The following is a description of a gene set: Human Gene Set: GSE27786_BCELL_VS_ERYTHROBLAST_UP Each fraction of mouse hematopoietic cells was purified by cell sorting from bone marrow of 8-week-old C57BL/6 mice, and its gene expression was analyzed. Genes up-regulated in comparison of B cells versus erythroblasts. from publication Konuma T, Nakamura S, Miyagi S, Negishi M, Chiba T, Oguro H, Yuan J, Mochizuki-Kashio M, Ichikawa H, Miyoshi H, Vidal M, Iwama A (PMID 21540074) studied in species Homo sapiens, and this is the list of marker genes: GALNT4, C3orf33, SBNO1, MFSD3, SLF2, PSMB4, NELFA, WASHC4, EDARADD, CCT7, POLR1C, NUDT18, C2orf68, FHOD1, NOP56, CFDP1, KMT5B, TAP2, CORO1C, SCAP, TRAF3IP2, KLF6, RAP2B, ZFP36, SRF, SNX19, RTCA, PJA1, CITED2, CNPY3, PGLYRP2, FAM91A1, ARB2A, MRPS31, CBX8, TM6SF1, CLUAP1, FLOT1, VPS45, CACUL1, LTN1, MAPK11, FKBP4, PIK3CG, MRPL45, AP3B1, SCAMP2, KCNQ1OT1, RCCD1, MED31, PDK1, PDPR, SIK3, CYP39A1, ZDHHC4, DGAT1, EFR3A, TSKS, MAGI2, SOCS7, ZNF48, TWNK, PRXL2B, ALKBH7, ZNF862, PLPP6, RHOT1, CWC15, FOXRED2, PIGF, GMDS, PRR3, IPCEF1, PDE4DIP, MBD1, PHB2, NTHL1, KLC1, UBXN4, NGRN, PDLIM1, CYP51A1, YWHAB, ENTPD5, ABHD6, COMMD8, ZNF383, GUSB, NDUFS3, OPA1, MLX, LMO4, ZDHHC9, CCR5, EBP, SF3A3, GYG1, FOXN2, ATP8B2, DDX46, DUSP16, TTC39B, ABHD11, BAX, LYAR, LONRF1, MED13, HSD17B4, OSM, ACP5, MAPK9, ECSIT, CENPS, MEF2D, IKZF1, IMP4, WDR77, STX16 (syntaxin 16), ALDH6A1, IER3IP1, PSMA3, PTPN2, CHML, UBA6, MANF, MCFD2, CHTOP, POMP, MRPL22, NFATC3, MNT, APPBP2, ACD, ZNF32, ATP5F1A, NABP1, PI4K2A, GLB1L, MRPS25, BCL2A1, KNOP1, PRKAB2, JAGN1, TRA2B, KCNK6, NOL8, STRAP, IMMP2L, NCOA2, GSKIP, RNF115, CHD3, STYX, PEX1, LENG9, NCOR1, API5, YIF1A, NUDT3, DDX39B, UBTD2, BCAR3, IFT172, TIMM21, ZNF771, RUVBL2, MLLT1, MDP1 (NCBI Gene Id 145553), TAPBP, LY9, DHX57, DCAF15, SAPCD1, C22orf39, TRAPPC3, TRAF3IP3, PTGR3, NAB2 (NGFI-A binding protein 2), BOLA2, STAMBPL1, BST2, AMN, ATP6V1H, KMT2D, MSMO1, STARD5, CPNE1, ALKBH1 (NCBI Gene Id 8846), HNRNPA3, DAG1, CREB3L2, H2AB2, RBM28, COX17, MIEN1, LGMN, BOP1, DDX27, PDXK, MRTFA